Given this list of marker genes TOM1, TET2, PDCD1, TRAC, CTPS1, MAGT1, TPP2, PRKCD, LAT, STK4, IKZF3, PIK3R1, IL2RB, CD28, TNFRSF9, CD27, ITK, DEF6, REL, ELANE, IRF1, PGM3, here is a description of the gene set: Any kind of test for an infectious agent in a specimen positive. species: Homo sapiens Positive infectious agent test Human Gene Set: HP_POSITIVE_INFECTIOUS_AGENT_TEST